The following is a description of a gene set: Mouse Gene Set: GOBP_REGULATION_OF_SPINDLE_ORGANIZATION Any process that modulates the rate, frequency or extent of the assembly, arrangement of constituent parts, or disassembly of the microtubule spindle. studied in species Mus musculus, and this is the list of marker genes: Chmp1b (charged multivesicular body protein 1B), Ripor2, Dctn1, Hnrnpu, Chmp3, Tpr, Hspa1a, Chmp4c, Psrc1, Parp3, Drg1, Rcc1, Chmp6, Mapk15, Spag5, Senp6, Chmp2b, Cenpj, Gnai1, Vps4b, Gpsm2, Pkd1, Fsd1, Tacc3, Ccsap, Tpx2, Cep97, Eml3, Chmp7, Chmp4b, Hspa1b, Rnf4, Dync1h1, Plk1, Bora, Chmp2a, Chmp1b2, Chmp5, Rae1, Sass6, Chmp1a, Map9, Stil, Ankrd53, Numa1, Cltc, Nup62